The following is a description of a gene set: species: Homo sapiens Human Gene Set: LEE_LIVER_CANCER_SURVIVAL_UP Genes highly expressed in hepatocellular carcinoma with good survival. We analyzed global gene expression patterns of 91 human hepatocellular carcinomas (HCCs) to define the molecular characteristics of the tumors and to test the prognostic value of the expression profiles. Unsupervised classification methods revealed two distinctive subclasses of HCC that are highly associated with patient survival. This association was validated via 5 independent supervised learning methods. We also identified the genes most strongly associated with survival by using the Cox proportional hazards survival analysis. This approach identified a limited number of genes that accurately predicted the length of survival and provides new molecular insight into the pathogenesis of HCC. Tumors from the low survival subclass have strong cell proliferation and antiapoptosis gene expression signatures. In addition, the low survival subclass displayed higher expression of genes involved in ubiquitination and histone modification, suggesting an etiological involvement of these processes in accelerating the progression of HCC. In conclusion, the biological differences identified in the HCC subclasses should provide an attractive source for the development of therapeutic targets (e.g., HIF1a) for selective treatment of HCC patients. Supplementary material for this article can be found on the HEPATOLOGY Web site (http://interscience.wiley.com/jpages/0270-9139/suppmat/index.html) from publication Lee JS, Chu IS, Heo J, Calvisi DF, Sun Z, Roskams T, Durnez A, Demetris AJ, Thorgeirsson SS (PMID 15349906), and this is the list of marker genes: C4BPB, FBXO31, RUNDC3B, PC, ZBTB22, SRD5A1, ACADS, TRIM55, F10, HSD17B10, ACOX2, ATP6V0E2, UGT2B4, ASGR1, MVK, CUX2, F13B, SLC27A5, PAH, ABCC2, ITPR2, RGN, MIR1-1HG, KHK, MPDZ, LDHAL6A, STARD10, S100A8, SLC2A2, UGT2B15, ABHD6 (abhydrolase domain containing 6, acylglycerol lipase), MST1, NDUFS2, SLC6A12, NDRG2, CES3, CGREF1, PINK1, HAO1, CCL16 (C-C motif chemokine ligand 16), CES2, APOC3, IVD, CRAT, EHHADH, MSRA, STK32B, DENND5B, PRDX6, A1CF, FMO3, HYAL1, SLC25A10, COQ8A (coenzyme Q8A), EPHX1, PIPOX, ATG16L1, OGDHL, OTC, TMEM176B, GJB1, MOGAT1, CYP2D6, CLRN1, ACSM5, NF1, SULT2A1, BAAT, UNKL, INSR, LPIN1, SLC38A3, EGLN2, TSKU, ABCG5, WNT11 (Wnt family member 11), DSG1, C1orf115, APOA5, KLK3, ITIH1, F12, CFHR5, PARD3B, INSIG1, DPYS (dihydropyrimidinase), CYP4F11, TACO1, CES1, CPB2, UGT3A1, SELENBP1, PHLPP1, CPN2, AGL, CRYL1, ZBED1, APCS, CABIN1, RETREG3, TTPA, SERPINF1, SLC35D1, ILRUN, MORN1, ANXA9 (annexin A9), RBP5, CDHR5, NECAB2, MTSS1, VPREB1, AR, ECHDC2, CAND2, HGD, AOX1, AMDHD1, HYDIN2, SEC14L2, MRM1, ABCA6, PCSK6, MASP2, HAGH, DEPDC7, BDH1, CPT2, SERPIND1, AMFR, NLGN1, WNK3, MAP4K1, FAM169A, DCXR, ACSL6, CYP2J2, COBLL1, HPD, PKLR, GLYAT, TTBK1, SPINK2 (serine peptidase inhibitor Kazal type 2), DIO1, LEAP2 (liver enriched antimicrobial peptide 2), PLPP1, G6PC1, CYP3A4, AMT, MRPL46, HSD17B6, UGT1A6, SLC22A18, SALL1, RPS2P45, SERPINC1, AMACR, PCYT2, ACSL1, MLXIPL, ALDH1L1, SGPL1, SERPING1, KNG1, MYRIP, FLJ30679 (NCBI Gene Id 146512), SEPTIN4, ABCG8, RDH5, ENPP5, CDO1, ALAS1, PCCB, CLTRN, AQP9, CSAG2, C2, PCK1, RHBG, ZBTB20, ECHS1, ALDH4A1, ZP3, C1QTNF4, DHRS3, RRN3P1, LINC02693, IL6R